The following is a description of a gene set: Failure to thrive Failure to thrive (FTT) refers to a child whose physical growth is substantially below the norm. Human Gene Set: HP_FAILURE_TO_THRIVE studied in species Homo sapiens, and this is the list of marker genes: NDUFS1, KDM6A, MAP3K20, NGLY1, SELENON, RNF2, MT-ND4, FH, STAR (steroidogenic acute regulatory protein), LARS1, MRAP, KCNJ11, PEX5, STAMBP, CHRNA3, RRM2B, DPAGT1, GALC, ORAI1, HLA-DQB1 (NCBI Gene Id 7924), EBP, DIAPH1, MTHFR, FGF12, PDX1, RBCK1, BUD23, GTPBP3, CUBN, KMT5B, TLK2, SMOC1 (SPARC related modular calcium binding 1), FLCN, TMEM126B (NCBI Gene Id 95018), ALOXE3, MVK, GCDH, GNPTAB, NAGS, SHOC2, CEACAM3, MMACHC, VRK1, LEMD3, FDFT1, MRPS2, POLR3K, MMAA, DOCK6, BTK, SLC26A3, SRP54, ALG12 (NCBI Gene Id 79087), ORC4, RFXANK, PTPN11, SLC51A, PET100, ALOX12B (arachidonate 12-lipoxygenase, 12R type), BRCA1, DLD, GPR161, POLR1C, STX1A, TNFRSF11B, MTRR, SLC13A5, SLC34A1, SLC12A3, LYRM4, ZSWIM6, SLC39A13, SLC22A5 (NCBI Gene Id 6584), ALG9, LYN, RET, PKP1, RBPJ, IL7R, MT-TL1, TPI1, TCTN3, TCIRG1, EHMT1, NFKB1, KIF15, NALCN, C2orf69, ACD, UNC80, GMPPA, ASCL1, ACTA1, RRAGC, TBC1D24, ANKRD55, CNKSR2, STT3B, DPM1, DMXL2, PIGG, POGZ, SCNN1B, NIPBL, ALG8, SLC9A3, NDUFB11, ATP5F1A, GALM, COX5A (NCBI Gene Id 9377), CASZ1, MYMX, ZMPSTE24, AGPAT2, GTF2I, TXNRD2, COX4I2, NCAPG2, EP300 (E1A binding protein p300), FTO (FTO alpha-ketoglutarate dependent dioxygenase), SLC1A3, BAZ1B, LIG4, FOXP1, SLC35A2, SLC32A1, SSR4, G6PC3, FBXO28, PIGQ, SMPD1, FCGR2A, AQP2, SYT2, POLR1D, HFE, IL21, ZIC2, COG1, GABRG2, GTF2H5, MT-TQ, NRCAM, LUZP1, STING1, NDUFAF4, CACNA1A, PLCB1, NDN, CRELD1, SKI, PHKG2, CYP17A1, CARS2, PDGFRB, CYB5A, GBE1, KCNT1, SETD2, NUP54 (nucleoporin 54), ERCC8, SLC25A4, GTF2IRD2, SBDS, SCN3A, ETHE1, PNKP, TNFRSF13B, POU1F1, KMT2D, ATP6V1A, ZEB2, ABCA3, DPYS, AP3B2, NSD2, COG7, KIF7, HIVEP2, TOPORS, BRD4, PPFIBP1, BCAP31, HSD17B4, CR2, TINF2, PYGL, UNC45A, GLYCTK, IRF2BP2, SERAC1, SNX10, PI4K2A, MCTP2, SGO1, SOX9, SURF1, HIBCH, PREPL, LAMC2, TMEM106B, TWIST2, PROKR2, NONO, TMEM70, TRAC, WDR11, LMNA, EXOSC3, PEX6, NDUFV1, VPS53, TAF6, IGHM, GYS2, SLC25A21, ASXL3, KRT6A, CD40LG, CHD7, WNT2B, GSTM3, SYNJ1, TBR1, MYO5B, EIF4A2, GABRB2, AAAS, SLC46A1, UFD1, NDUFA8, MT-TN (mitochondrially encoded tRNA-Asn (AAU/C)), AKT1, NUBPL, AGR2, ECE1, DGUOK, KRT17 (NCBI Gene Id 5103), SEC23B, TRAK1, NDP, OTUD6B, KCNC2, PEX7, SPTBN1, NDUFA6, HNRNPK, CD3G, NDUFA13, COX7B, SAR1B, SLC6A8, SCN2A, VPS51, ALAD, NR0B1, GOLGA2, KCNQ2, KANSL1, ADH5, TCF4, RERE, ZIC3, AGPS, MEGF10, MECR, ERCC3, LRBA, UQCC2, SLC25A19, DNASE2, ASAH1, ACTG1, ERMARD, GJA5, PAX2, TPM3, FKBP6, ORC6, COL4A5, CDKL5, GNPAT, FANCF, CERS3, SLC30A9, PHKA2, GTPBP2, WWOX, ABCC8, CTNS, PNPT1, UBA2, HMGA2, CTCF, SLC2A2, CASK, EVC, LAMA3, KMT2C, ZNF668, MT-ATP6, TAFAZZIN, ATP1A3, NLRC4, PIK3CA, ADA, PACS1, RNF13, DNM1L, FIG4, ABCB11, VPS33B, WDR4, CA12, PUS3, ACOX1, MGAT2, HCCS, ERBB3, ATP9A, RNU4ATAC, CEACAM6, FOXRED1, KCNA2, CDT1, COL7A1, CDC6, COL6A1, TALDO1, SPI1, RAG2, TNFRSF13C, HLA-DQA1, PEX10, STRA6, CD96, TCOF1, GRM7, MT-ND5, DPYD, COL4A6, NR1H4, PRKACB, ORC1, INSR, SKIC3, CHRM3, PARS2, FTH1, HBA2, CFTR, POLR2A, BANF1, PEX12, IGHMBP2, USF3, CACNA1B, CBS, CD3D, MCCC2, JAG1, HEXB, METTL27, SMARCD2, AASS, PSMB8, AMN, HADH, CLCNKB, GATM, PIEZO2, PIGP, RYR3, SFTPB, GRIA4, UBR1, EDNRB, TRMT5, MTTP, LRRK1, GNB2, NEUROD2, NDUFAF2, SPOP, JMJD1C, SMAD4, CD3E, CAV1, NUS1, MMP23B, CYFIP2, POLR1B (RNA polymerase I subunit B), NLRP1, HYMAI, CARMIL2, KCNN4, FOXH1, MARS1, FOXN1, PHOX2B, MED17, TFAM, IL2RA, EPG5, STAG2, GABRA5, ARID1B, TNPO2, RMRP, NSMCE3, PDPN, EXOSC9, TGFB1, MMUT, SEMA3C, PTDSS1, SYNGAP1, RAPSN, AK2, IFT56, GJA8, CTBP1, TMEM216, COX4I1, HNRNPH2, H19, CAVIN1, MYT1L, HDAC8, CHRNG, PRKCZ, AHCY, KIAA0586, CLCNKA, RIPK1, LMBRD1, RFC2, POLA1, TERT, KCNJ1, HCN1, H3-3B, TBX1, DHDDS, CENPT, FGFRL1, RYR1, SNORD116-1, CPS1, FGF8, HSPG2, COMT, POC1A, CDC45, EIF5A, XPC, MDH2, OFD1, TGM1, ELN, ABCD4, DACT1, HCFC1, PRDM16, ZNF699, MKKS, CD79A, DGAT1, OTC, NFKB2, ERCC1, CAPNS1, CD247, MT-TW, TK2, EPCAM, ARVCF, ACTL6B, SFTPC (surfactant protein C), POMC, MICOS13, POLR1A, PLP1, PCCA, GABRA2, CARS1, MRPL39, TMEM270, ASS1 (NCBI Gene Id 445), CREBBP, NSUN3, SLC6A14, EXTL3, STAT5B, NCF1, ARPC1B, PNPO (pyridoxamine 5'-phosphate oxidase), PEPD, ADK, DYNC2LI1, TCN2, RTEL1, AMER1, UBAP2L, SZT2, EOGT, MKRN3, CLDN16, ADAR, DHX9, SPTSSA, ASXL1, GAA, TTN, ZAP70, PEX16, HNRNPH1, MRPS28, DALRD3, TMEM231, INS, RPL5, SMC1A, NDUFS3, SLC25A13, SLC25A15, CACNA2D1, CYP24A1, KCNB1, NEXMIF, NDUFS2, PGM3, PTF1A, MTO1, CRIPTO, HSD11B2, FOS, AARS1, NUP214, SEC31A, SCNN1G, NPAP1, MIF, YARS1, GABRD, CDON, HESX1, IL21R, NDUFA11, HMOX1, ATP8B1, ELAC2, GDNF, AHDC1, TBL1XR1, MMAB, IVD, YARS2, NFE2L2, PACS2, EARS2, NPHP3, VHL, ALG3, STIL, MAP3K7, CLCA4, NOTCH1, PRPS1, ERBB2 (erb-b2 receptor tyrosine kinase 2), SLC39A4, TRIM8, AKR1D1, KRT6B, UBA5, DSG1, HBB, KDM5C, DNM1, NHLRC2, SLC39A7, ATPAF2, SDHD, SCNN1A, MMADHC, TYMS, PTRH2, NELFA, DHCR24, HPDL, MCCC1, SMAD2, DRG1 (developmentally regulated GTP binding protein 1), B4GALT7, EBF3, KRT14, IRF8, EFL1, MT-ND6 (mitochondrially encoded NADH:ubiquinone oxidoreductase core subunit 6), NOTCH2, LIPA (NCBI Gene Id 3988), RREB1, CD19, PRDX1, STAT3, TFRC, GGPS1, B3GALT6, FZR1, PNPLA1, RBM10, COPB2 (NCBI Gene Id 9276), CLIP2, SI, EIF4H, SLC35C1, PUS1, LIMK1, CBL, LMNB1, SLC1A2, BSCL2, PEX2, SLC26A9, IKBKG, COX10, ATP6AP1, AIMP1, IL2RB, MT-TV, CBFB (core-binding factor subunit beta), TRAPPC2, CSNK2A1, GALE, SMARCAL1 (NCBI Gene Id 50485), NDUFA2, IGF1 (NCBI Gene Id 3479), ERCC4, DYM (dymeclin), FMR1, HRAS, VAC14, MSMO1, RAG1, GFAP, MRPL12, RFT1, CENPJ, SLC12A5, NACC1, GLUD1, SEC24C, SERPINA1, MT-ND1, TMEM165, BRF1, AUH, RNU7-1, RPS19, PLCB4, SNRPN, RIT1, MIPEP, EXOSC8 (exosome component 8), COQ4, POMP, IGF2 (NCBI Gene Id 492304), VPS13B, ABCD1, PTPN2, CUL3, KCNAB2, POLR3A, MCEE, NDUFB10, CAD, CSPP1, SH2B1 (NCBI Gene Id 25970), NDUFAF3, GCLC, DLL4, FLNA, MT-TH, PEX11B, CYC1, GRIN2D, HADHB, DLL1, GPIHBP1, DEAF1, IL1RN (interleukin 1 receptor antagonist), GJA1, NNT, COG8, NDUFS4, CELF2, GNB1, ABCA12, GPD1, SEMA3D, UBE4B, ALDH18A1, TRIO, SRD5A3, PRMT7, NDUFV2, FBN1, SPEN, DHCR7, NFIX, NUP62, ENPP1, PWRN1, GJB6, ALG6, PSMB4, SLC25A3, TMPRSS15, SLC3A1, SLC16A2, PEX19, SLC9A6, HBA1, DCTN4, PIK3CD, DSP (desmoplakin), SIM1, BMPR1A, DNAJC30, FOXP3, FAM111A, ERCC5 (ERCC excision repair 5, endonuclease), ROBO1, TOM1, CA2, UFC1, BRAF, TBL2, AFG2A, NDUFAF1, SLC39A8, MBTPS2, KLLN, ACVR1, SHH, MAPKAPK5, TWNK, SP110, ACADS, TJP2, DDB2, CLTC, PEX1, DPP9, SALL1, COL12A1, ERCC2, KARS1, LYRM7, ALG11, TKFC, SULT2B1, PEX26, ARFGEF2, MTRFR, HTRA2, ATP6V1E1, LCK, MARS2, HERC2, AGTPBP1, PBX1, SMARCA2, MYL2, PIGA, LBR, PPARG, NR4A2, DOCK8, SMC3, SLC10A2, SLC17A5, IFNG, SIL1, ATP7B, MRPS14, EFEMP1, AARS2, DYNC2I1, CIITA, TGFB3, STRADA, LHX4, SLC25A46, CPLANE1, NDUFB8, MPDU1, SLC4A1, FGFR1, SLC25A22, DPM2, NDUFB3, PRF1, MBL2, GNAO1, PTEN, SLC34A3, ITGA7, SUGCT, NSRP1, ATP6V0A2, FDXR, MYMK, PNP, MT-CO3, ADAM17, ZNFX1, TIMM50, KRT5 (keratin 5), SH3TC2, PCSK1, FAH, HADHA, AVPR2, IFT140, FUCA1, STT3A, ICOS, DDOST, MLXIPL, PMPCB, STAT4, HSD3B2, SDR9C7, MT-CYB, OTULIN (OTU deubiquitinase with linear linkage specificity), SPINK5, MT-ND2, GBA1, SLC38A3, DDC, BLNK, ALDOB, EVC2, PDE6D, YWHAG, MTR, CYP11B2, ACAD9, FAM149B1, MYOD1, POLG, SETBP1, DKC1, GJB2, SLC5A1, VPS45, TGIF1, RNU4-2, TRIT1 (tRNA isopentenyltransferase 1), MC2R, ATP7A, LAT, ST3GAL5, BMP4, NSUN2, KAT6B, ASL, KIAA0753, SCO2, JAGN1, GTF2IRD1, AP1B1, SNAP29, FOCAD, SCN1B, PCGF2, MS4A1, LGI3, CYP7B1, RAC2, SLC25A24, TLL1, SV2A, PYCR1, PLAGL1, MAGEL2, CSF2RB, ATP1A2, XPA, GATA6, MECP2, MRPL3, OCRL, CAMKMT, CLCN3, CPSF3, BCS1L, NTRK2, NDUFS7, RARS2, MYH3, SLC4A10, ASNS, GP1BB, GABBR2, OCA2, HACD1, SKIC2, BPTF, WDR26, AMACR, SREBF1, ADNP, PIK3R1, GCK, ERCC6, PHGDH, TCF3, PSAP, MT-CO1, PEX14, VPS37D, SMO, DEGS1, NDUFAF8, NDUFA1, GALT, HPD, KRAS, GRIN1, IDH1, PPP3CA, COG6, RAB3GAP1, NDUFS8, LTC4S, AGXT, EDN3, NFKBIA, RARB, GRB10, MRPS7, SCN8A, KRT16, TIMMDC1, RTTN, DCLRE1C, MT-ND3, PSMC1, PPP1R13L, PLAA, HSD3B7, DNAJC19, ITCH, USP7, DNMT3B, EPRS1, PEX3, ANTXR2 (NCBI Gene Id 118429), PPP1CB, VDR, NDUFA4, LINS1, DNAJC21 (NCBI Gene Id 134218), PIGB, ANO1, UMPS, OCLN, KCNJ6, CD79B, PSMD12, MPI, NDUFB9, ADAT3, IKBKB, ELMO2, MT-CO2, ABCC6, PRKACA, NRTN, ATXN7, PARN, SLC11A1, GPT2, UBE3B, OSGEP (O-sialoglycoprotein endopeptidase), SNORD115-1, MT-TF, ACO2, CLMP, NKX2-1 (NCBI Gene Id 7080), FGD1, CDK19, POLG2, IARS1, LPIN2, NCF2, PERCC1, BSND (NCBI Gene Id 7809), MAP2K1, EN1, DISP1, ABL1, SLC7A7, SLC37A4, CASP8, DYRK1A, TPM2 (NCBI Gene Id 7169), SON, SUCLA2, IRF1, PCCB, SLC12A1, MT-TK, HIKESHI, KIF1B, ARHGAP31, PDHX, ATP6V0A4, MYH7, FARSB, NFASC, NECAP1, LAMB3, ACSL5, SCO1, HIRA, CASR, GLB1 (galactosidase beta 1), FLII, ARCN1, PSMB10, BICRA, SIN3A, RECQL4, SUCLG1, PPM1B, NDUFAF5, CPLX1, ATM (NCBI Gene Id 8068), SIK1, ADCY5, COA8, RFXAP, GAS1, RFX5, DOCK11, DOLK, PWAR1, VPS37A, TGDS, SDHB, ALPL, NEUROG3, GMNN, NR3C2, ZFP57, AFF3, IL2RG, KCNA1, CYP27B1, NFIA, PLCH1, ATP5F1B (ATP synthase F1 subunit beta), SIX3, BRCA2, KMT2A, TAOK1, NIPAL4, NADK2, SDHC, IGLL1, SCN1A, FUT8, CYP11A1, MPV17, JAK1, RASGRP1, RELB, NFU1, LRRC8A, TASP1, JAK3, PTPN22, RAD21, NEDD4L, FOXG1, PSAT1 (NCBI Gene Id 29968), COG4, TNFSF12, FBXL4, GLI2, VIPAS39, CYP2R1, WDR62, IPO8, RAI1, SARS2, LETM1, PMM2, TRMT10C, SC5D, MED12, NDUFS6, ARX, WNT7B, CSF2RA, EEF1A2, TAMM41, PEX13, PTCH1, IQSEC2, MT-TS2, TBX4, CD81, EDNRA, H4C5, ACSF3, MCM4, SMARCC2, MAP2K2, STAG1, TSHB, GLI1, CIT, GALK1, LRPPRC, TRAPPC11, PYCR2, ACTB, PGAP1, NODAL, EGFR